The following is a description of a gene set: Mouse Gene Set: GOBP_PYRIMIDINE_NUCLEOBASE_TRANSPORT The directed movement of pyrimidine nucleobases, one of the two classes of nitrogen-containing ring compounds found in DNA and RNA, into, out of or within a cell, or between cells, by means of some agent such as a transporter or pore. studied in species Mus musculus, and this is the list of marker genes: Aqp9, Slc29a2, Slc28a1, Slc29a1, Slc29a3, Slc28a3